The following is a description of a gene set: A protein complex produced by sequentially activated components of the complement cascade inserted into a target cell membrane and forming a pore leading to cell lysis via ion and water flow. studied in species Mus musculus Mouse Gene Set: GOCC_MEMBRANE_ATTACK_COMPLEX, and this is the list of marker genes: C9, C8g, C8b, C6, C8a, Hc, C7